Given this list of marker genes Adcy3, Adcy7, Gnb4 (guanine nucleotide binding protein (G protein), beta 4), Adcy1 (NCBI Gene Id 52867), Adcy5, Gnaz, Adcy6, Gng2, Gngt2, Gng13, Gng12, Gng10, Gng4 (guanine nucleotide binding protein (G protein), gamma 4), Adcy8, Gng5, Gnb2, Adra2c, Gng7, Gngt1, Gnb3, Adra2b (adrenergic receptor, alpha 2b), Adcy2, Rgs20, Rgs17, Gng3, Adra2a, Rgs16 (NCBI Gene Id 19734), Gng8 (guanine nucleotide binding protein (G protein), gamma 8), Adcy4, Gnb1, Gnb5, Gng11, Adcy9, here is a description of the gene set: species: Mus musculus Mouse Gene Set: REACTOME_G_ALPHA_Z_SIGNALLING_EVENTS G alpha (z) signalling events